The following is a description of a gene set: Human Gene Set: GOMF_ATPASE_ACTIVATOR_ACTIVITY Binds to and increases the activity of an ATP hydrolysis activity. studied in species Homo sapiens, and this is the list of marker genes: DNAJA2, NKRF, ATP1B3, ATP4B, DNAJC1, GTF2H4, DNAJA1, DNAJC24, DNAJB6, DNAJB1, DNAJC2 (NCBI Gene Id 378162), AHSA2P, AHSA1, DNAJB4, DNAJC10, FXYD2, DNAJC19, DNAJB2, DNAJC7, HSCB, DNAJC15, TOR1AIP1, ATP1B2, TOR1AIP2, MYBPC3, ATP1B1, ATP6AP1